The following is a description of a gene set: Enlarged ovaries studied in species Homo sapiens Human Gene Set: HP_ENLARGED_OVARIES, and this is the list of marker genes: USF3, STK11, CYB5A, PIK3CA, MID1 (NCBI Gene Id 8230), KLLN, SDHB, CYP19A1, CYP17A1 (NCBI Gene Id 1586), INSR, SDHD, PTEN, SEC23B, FSHR, POR (NCBI Gene Id 96440), ESR1, AKT1, SDHC